Given this list of marker genes ACSM1, HNRNPA2B1, APIP, SEMG1, ARHGEF9, FAM98B, FNBP1L, RHBDL3, C8orf76, PHC1, LARP1B (La ribonucleoprotein 1B), ABCB10 (NCBI Gene Id 23456), ESCO1, H2AC6, AAK1 (AP2 associated kinase 1), AMOTL2, E2F3, USH1G, ALG2, TNFRSF21, TWF1 (twinfilin actin binding protein 1), FRYL, PPP1R14A, MAP3K21, NBEAP1, DAZL, PALS2, H2BC6, STX10, FSIP1, PTPN11, CCDC136, GFUS, TNS3, ANKRD10, RNGTT, GALR2, HIP1 (NCBI Gene Id 3092), CEP44, TTL, ASXL1, NAPSA, SLF1, VPREB3, HPF1, WASF1, RNF180 (NCBI Gene Id 285671), SUSD1, FAP, LAMP2, DOCK7, GNB4, ZNF177, SOX4, URB2, MAGEH1, SGO2, SNRNP27, SLC22A4, GPR31, RNF39, ANXA4, FMO2, SMIM7, RABGGTB, RYK, LYPLA1, ITM2C, GMFB, CKAP2, EPB41, DDX21, KDM1A, SSX2IP, HES1, TAPT1, SERPINB12, SYDE2, PRDM7, GNG3, TOR1AIP1, LEPROT, PTPN2, SLC12A6, USP32P2, LHFPL2, AP3M1, SLC2A1, ZNF880, TLR7, IL3, SMAP1, LAPTM4B, LEMD3, CFAP263, SIAH2-AS1, BCDIN3D-AS1, CCDC14, HRK, TMCO6 (transmembrane and coiled-coil domains 6), PELI2, TMEM263, SRD5A1, KBTBD8, SOS1 (NCBI Gene Id 7838), GPATCH2, NID1, ITGAM, HAUS3, KLHL28, GUSBP5, IFT52, CHUK, NOL12, JKAMP, OGFRL1, TBC1D31, SLC5A3, BLM, C1D, MON1B, COX5A, TMSB15B-AS1, PRRG1, VPS26A, CSGALNACT2, CYP2C19, TAF5, GCA, GRHPR, TLN2, C1orf174, ATXN7, MC5R, ABTB3, CHCHD1 (coiled-coil-helix-coiled-coil-helix domain containing 1), ZEB2, MTHFD2L, RBBP6, TIGAR, GALNT3, CAPZA2 (NCBI Gene Id 830), UGT2A3, CCDC141, PAXBP1, TSPAN6, SYF2, OR1Q1, SRPX2, PAX8-AS1, ZFAND3 (NCBI Gene Id 60685), CUL4B, MRPL47, RNFT2, MTMR6, MGAT5B, TAS2R19, MAD2L1, AKAP3, LNX2, CCDC127, CENPU, CHMP4C, TRA2B, CPD, EMB, CDK6, DHRS3, FLJ13224, STS, ME2, NSUN3, FAM91A1, TCP10L3, SNX30, FBXO5, GPR18, DEFB114, TIFA (NCBI Gene Id 92610), PJVK, KPNA3, RHOBTB1, RALGAPA1 (Ral GTPase activating protein catalytic subunit alpha 1), LEF1 (lymphoid enhancer binding factor 1), SORD, ALOX5AP, UGT2B4, UHRF1, ORMDL3, LSM3, SDCBP, BRINP2, FAM241A, MAEL (maelstrom spermatogenic transposon silencer), here is a description of the gene set: Genes down-regulated in CD11b+ cells from BALB/c mice bearing C26GM colon carcinoma: spleen of BALB/c mice: spleen versus tumor infiltrating monocytes. Human Gene Set: GSE21927_SPLEEN_VS_C26GM_TUMOR_MONOCYTE_BALBC_DN from publication Marigo I, Bosio E, Solito S, Mesa C, Fernandez A, Dolcetti L, Ugel S, Sonda N, Bicciato S, Falisi E, Calabrese F, Basso G, Zanovello P, Cozzi E, Mandruzzato S, Bronte V (PMID 20605485) Tumor growth is associated with a profound alteration of myelopoiesis, leading to recruitment of immunosuppressive cells known as myeloid-derived suppressor cells (MDSCs). Analyzing the cytokines affecting myelo-monocytic differentiation produced by various experimental tumors, we found that GM-CSF, G-CSF, and IL-6 allowed a rapid generation of MDSCs from precursors present in mouse and human bone marrow (BM). BM-MDSCs induced by GM-CSF+IL-6 possessed the highest tolerogenic activity, as revealed by the ability to impair the priming of IFN- -producing CD8+ T cells upon in vivo adoptive transfer. Moreover, adoptive transfer of syngeneic, GM-CSF+IL-6-conditioned MDSCs to diabetic mice transplanted with allogeneic pancreatic islets resulted in long term acceptance of the allograft and correction of the diabetic status. Cytokines inducing MDSCs acted on a common molecular pathway. Immunoregulatory activity of both tumor-induced and BM-derived MDSCs was entirely dependent on C/EBP transcription factor, a key component of the emergency myelopoiesis triggered by stress and inflammation. Adoptive transfer of tumor antigen-specific CD8+ T lymphocytes resulted in therapy of established tumors only in mice lacking C/EBP in myeloid compartment. These data unveil another link between inflammation and cancer and identify a novel molecular target to control tumor-induced immune suppression. We used gene expression analysis to identify those factors, secreted by tumor-infiltrating MDSC, which could drive emathopoiesis. Moreover we compare gene expression profile of tumor-induced MDSC, obtained from either the spleen and the tumor infiltrate of tumor bearing mice, and in vitro bone marrow-derived MDSC. studied in species Homo sapiens